The following is a description of a gene set: Transcription of rRNA genes is controlled by epigenetic activation and repression. About half of the roughly 400 rRNA genes are expressed and these have the modifications of active chromatin: unmethylated DNA and acetylated histones. Repressed genes generally have methylated DNA and histone H3 methylated at lysine-9. Regulators of repression include the eNoSC complex, SIRT1, and the NoRC complex.<br> SIRT1 negatively regulates rRNA expression as a subunit of the eNoSC complex, which deacetylates histone H3 and dimethylates lysine-9 of histone H3 (H3K9me2).<br>NoRC negatively regulates rRNA expression by shifting a nucleosome near the start of rRNA transcription into a more repressive location and recruiting Histone Deacetylase 1 and 2 (HDAC1, HDAC2) and DNA Methyltransferase 1 and 3b (DNMT1, DNMT3b). Reactome Pathway: Negative epigenetic regulation of rRNA expression part of: Epigenetic regulation of gene expression studied in species Homo sapiens, and this is the list of marker genes: H3-3A, GTF2H5, UBTF, H2BC13, POLR1H, SUDS3 (NCBI Gene Id 64426), GTF2H2, POLR2H, SAP130, H3C1, CCNH, ARID4B, ERCC3, H2BC11, 18S rRNA, 5.8S rRNA, 28S rRNA, 28S rRNA, DNMT1, H2AZ2, 5.8S rRNA, H2AC7, H2BC21, ERCC2, BAZ2A, SIN3B, H2BC3 (NCBI Gene Id 3018), H2BC5, POLR2F, HDAC2, DNMT3B, H2AJ, H2AC18, POLR1A, H2AB1, H2AC4, H3C15, MNAT1, TAF1C, HDAC1, POLR1C, H2BC17, SAP30, POLR2L, TAF1A, SIRT1, H2BC12, H2AX, H2BC9, H2AC14, GTF2H4 (NCBI Gene Id 2968), TAF1B, TBP, H2BC26 (H2B clustered histone 26), H4C1, H2BC1, POLR1D, POLR1B, H2BC4, MBD2, POLR2E, SAP30L, SIN3A, SAP30BP, CDK7, RRP8, GTF2H1, H2BC12L, H2BC14, GTF2H3, TAF1D, POLR1E, H2AC20, TTF1, POLR1F, SUV39H1, POLR1G, H2BC15, SMARCA5, H2AC6, POLR2K, 5S rRNA, SAP18, 45S pre-rRNA gene